Given this list of marker genes GATA6, DPPA4, PRDM14, PBX1, SMAD4, CDX2, SALL4, TSC22D1 (TSC22 domain family member 1, NCBI Gene Id 8848), STAT3, NR5A1, EOMES, POU5F1, EPHA1, ZIC3, NANOG, ZSCAN10, DKK1, LIN28A, KLF4, HIF3A, FGF2, FOXP1, SOX2, GSC, HHEX, EPAS1, SMAD2, NR6A1, CRIPTO, FOXD3, SALL1, here is a description of the gene set: species: Homo sapiens Transcriptional regulation of pluripotent stem cells Human Gene Set: REACTOME_TRANSCRIPTIONAL_REGULATION_OF_PLURIPOTENT_STEM_CELLS